The following is a description of a gene set: studied in species Homo sapiens The formation of a protein hexamer, a macromolecular structure consisting of six noncovalently associated identical or nonidentical subunits. Human Gene Set: GOBP_PROTEIN_HEXAMERIZATION, and this is the list of marker genes: SPAST, UGDH, LRRC8A, MAT2A, LRRC8D, LRRC8C, LETM1, YME1L1, TWNK